Given this list of marker genes Spopl, Sgce, Golga7, Tmem132c, Lrfn5, Kl, Gria3, Slc25a46, Rnf139, Tnpo1, Ccdc126, Arhgap44, Pdha2, Bcl11a, Nova1, Osbpl8, Nkain3, Arl13b, Ptprf, Pcdh11x (protocadherin 11 X-linked), Rab23, Rbm12, Phlpp1, Ankle2, Sash1, Prpf4b, Tmed9, Cdyl2, Thsd7a, Cdh2, Nucks1, Gtf2a1, Slc12a5, Xntrpc, Ythdf3, Synj2bp, Ptbp3, Vezf1, Epha5, Bltp3b, Dpys, Nip7, Klhl2, Cacnb4, Dhx36, Mplkip, Hapln1, Pdlim5, Chic1, Cdk12, Rbm46, Kcnv1, Pank3, Gpr22, Zfp597, Reep1, 1700066M21Rik, Mllt1, Fnip2, Eif5a2, Atxn7, Cyp26b1, Gdf6, Arhgef12, Prkn, Septin11, Dmxl2, Rspo3, Msx1, Ralbp1, Spatc1l, Nsd3, Grk2, Copb1, Naaladl2, Ube2v2 (ubiquitin-conjugating enzyme E2 variant 2), Mier3, Gcfc2, Pdzrn4, D6Wsu163e, Rpgr, Ppp3r1, Gria2, Slc35b3, Pou3f2, Ep300, Uba2 (ubiquitin-like modifier activating enzyme 2), Nkain2, Hsp90aa1, Aplp2, Klk11, Hectd2, Plekhg4, Bicral, Gabra4, Serpinb2, Trim2, Phip, Unc13c, Kif21a, Tfap4, Crim1, Mphosph9 (M-phase phosphoprotein 9), Pde8b, Pcdh7, Spag9, Zdhhc15, Zfhx4, Eif5a, Tlk2, Qser1, Mblac2, Kcnj3, Notch1, Dcx, Zfhx3, Tmem181a, Trappc2, Slc8a1, Zfp799, Mvb12b, Mindy3, Zfand4, Atg3, Fam204a, Gab1, Fignl1, Rps6ka3, Braf, Slc10a7, Neurod6, Psd3, Tbc1d30, Med12, Bcat1, Ino80d, Gzf1, Elovl7, Wwtr1, Raph1, Dmrt1, Nap1l2, Dgat2, Ctnnd2, Syt14, Aqp4, Snrnp48 (small nuclear ribonucleoprotein 48 (U11/U12)), Ptpdc1, Lce1f, Mapk1ip1l, Errfi1, Scai, Gm20816, D630023F18Rik, Atat1, Plppr4, Hoxa5, Tmem33, Corin, Tent5a, Chfr, Dclk1, Prl3b1 (NCBI Gene Id 18776), Pik3cb, Osbpl6, Cdh20, Prkaa2, Pex13, Atrx, Lemd3, Nod1, Glce, Yeats2, Ckap4, Slc2a2, Fzd8, Prickle1 (prickle planar cell polarity protein 1), Nr4a3, Cnot6, Megf11, Ptgfr, Dcun1d3, Scg2, Chm, Ppp2r5e, Nadk2, Htatsf1, Onecut2, Tubb5, Kdm4a, Mef2d, Foxo1, Npas3, Rbm41, Slc4a7, Camta2, Hycc2, Stx16 (NCBI Gene Id 99409), Etv1, Rhoq, Phf19, Lclat1, Ndufaf5, Rfx7, Fnip1, Ppm1e, Rsrp1, Gcnt2, Mat1a, Pramel3b, Adamts7, Klra1, Nsrp1, Cbx5, Ppargc1a, Topors, Cdk6, Edil3, Lysmd3, Cnot7, Fat4, Pds5b, Dkk4, Cep350, Bclaf1, Dgkb, Phc3, Gal3st4, Nmt2 (NCBI Gene Id 99235), Etnk1, Thumpd1, Ssh2, Fsd1l (fibronectin type III and SPRY domain containing 1-like), Tm9sf2, Vegfa (NCBI Gene Id 22339), Clasp1, Cox15, Kcnh5, Rc3h1, Hnrnpr, Adgrl2, Arih1 (NCBI Gene Id 23806), Itga6, Cpeb4, Rundc3b (NCBI Gene Id 242819), Azin1, Syt4, Tbl1xr1, Elavl1, Bhlhe22, Notch2, Lpp, A830018L16Rik, Tmeff2, Tmod2, Bzw1, Satb1, Elmod2, Tmco3, Polr3gl, Slc4a4, Nudt5, Caap1, Usp38, Nhsl1, Cdca2, Pcdh9, Lztfl1, Tmem41b, Slc7a7, Med12l, Polr3a, Gm15881, Ppp4r3a, Tet1, Cpeb2, Fzd3 (frizzled class receptor 3), Myf5, Arhgap42, Cdk17, Ahr, Tmem123, Ehf, Fstl1, Mcoln2, Pcdh18, Hp1bp3, Snrnp40, Pdzd8, Rap1gap2, Rnf111 (ring finger 111), Cers6, Scel, Ammecr1, Mycs, Prelid3b, Il13ra1, Gopc, Ids, Cadm2, Gpm6a, Ckap2l, Trip11, Ddx3y, Nufip2, Cir1, Ufm1 (NCBI Gene Id 99652), Uhmk1, Caprin1, Scp2, Tasl, Hnrnpc, Ptpra, Dact1, Jrkl, Adora3, Mast4, Btf3l4, Snap23, Ccnb1ip1, Fkbp7, Vmp1, Orc1, Cdc14a, Foxn2, Map3k2, Cep170, Tnfaip6, Zfp804a (NCBI Gene Id 241514), Xiap, Nbeal1, Zfp512, Tm9sf3, Pgap1, Myt1l, Bnip3, Cdc42, Htr1a, Klf8, Slco5a1, Cnot2, Gm5796, Csnk1a1, Tmem65, Rnf4, G3bp1, Fut9, Rmnd5a, Cog3, Nedd9, Rwdd3, Trp53inp1, Btbd10, Gcc2, Ola1, Chn2, Gpr149, Rimklb, Smim14, Smad5, Prkd3, Setd2 (SET domain containing 2), Casp6, Frmd3, Mycn, Cops7b, Car13, Tafa2, Hecw2, Tgfb2, Nf1, Fam13c, Pramel3e, Sdc2, Qtrt2, Pramel3c (NCBI Gene Id 434893), Pax9, Rag1, Ccdc92, Exoc5, Mindy2, Bnc1, Gfpt1, Mtdh, Zfx, Slc9a6, Nr5a2, Mbtd1, Zmym5, Akap6, Mrgprb2, Pramel3a, Klhl31, Herc2, Eef1e1, Pgk2, Lrba, Fgf14, Hspa5, Cbfb, Cask, St13, Agmo, Gca, Mgst1 (microsomal glutathione S-transferase 1), Camk2d, U2surp, Rab18, Pgr15l, Gtpbp10, Taf9b, Tbr1, Trpc2, Klf3, Syncrip, Arid4b, Cldn1, Hsf5, Ctdspl2, here is a description of the gene set: studied in species Mus musculus Mouse Gene Set: MIR_7A_1_3P Genes predicted to be targets of miRBase v22 microRNA mmu_miR_7a_1_3p in miRDB v6.0 with MirTarget v4 prediction scores > 80 (high confidence targets). from publication Chen Y, Wang X (PMID 31504780)